Given this list of marker genes PLAT, STX11, IRF8, CAPN2, GRHL1, SIAH2, GCH1, SCGN, SWAP70, MORF4L2, NT5C3A, ZNF837, MFSD2A, DDX60, CRACD, BID, PSMA6, INSIG1, CLCF1, PIM2, CHST7 (carbohydrate sulfotransferase 7), FJX1, TFPI2, TUBB2A, LILRA5, GUCY1B1 (NCBI Gene Id 2983), HSPA13, MAP3K8, TNIP1, FLJ13224, HERC6, MAPKBP1, CD274, CXCL10, WARS1, GRAMD1A, RAB3IP, MMP7, ETV3, SOCS3, GALNT3, RIGI, REL, NAMPT, BCL2, RDX (radixin), PGM3, DDX60L, NETO2, COBLL1, MAP4K4, DYNLT1, LAMA3 (NCBI Gene Id 3909), IL15, IFI27, UBE2Z, KCNJ2, HOMER1, GPR137B, NFKB1, PELI1, EIF2AK2, HIVEP1, BATF, DPP10, WNT4, IDO2, VEGFD, NBN, LYRM1, RAB21, CMTM6, ZBTB17, RPS6KC1, SPRED2, AMIGO2, IRF1, DESI1, AK4, TRAFD1, RGS1, HES4, TNFRSF4, C15orf48, LILRA3, EZH2, LTA, SERPINB1, PXDC1, C17orf58, LINC00930, CLDN1, TNFAIP8, DUSP5, TNFSF8, PLXNC1, PRKAG2-AS2, SELENOI, RELB, BRPF3, MYO10, HLA-DOB, SYNE3, OAS2, TNIP3, SERPINA1, ANKRD22, TBC1D13, AK8, TRIM69, C4orf46, EXT1, UAP1, MT1M, CXCL9, RYBP, IFNB1, AIM2, NUB1, MIR3945HG, RIPK2, IL36G, NEMP1, VCAN, LYSMD2, ALOX15B, JAM2, NEDD4L, SESN3, OPTN (optineurin), GPR157, SNHG15, STAT4, BTG3, LAMB3, IRF7, RAPGEF2, IFIH1, PTGER4, CNKSR3, RHCG, PDE4DIP, TNFAIP2, BIRC2, EHF (NCBI Gene Id 26298), CMPK2, RFTN1, DNAAF1, SERPINB7, SOS1, CCRL2, BTG1, CD200, CHAC1, TARP, RPL36AL, TDRD7, ZNFX1, IFNL1, USP18, ICAM1, TXNL4B, RSAD2, GADD45B, DUSP4, LYN, IFIT1, IRAK2, CXCL3, ADRA1B, SAT1, SEC61G, ITGB8, IQCG, OXTR (NCBI Gene Id 5021), TMEM41A, CSRNP1, NDP, SELENOK, ARAP2, KCNA3, GADD45A, USP12, NCK2, CXCL11 (NCBI Gene Id 6373), LINC02381, DUSP1, NCF1C, PGAP1, TXN, CLDN16, RETREG1, CD70, TOMM34, PARP14, TPBG, UNC5C, here is a description of the gene set: Toll like receptors (TLRs) sense microbial products and initiate adaptive immune responses by activating dendritic cells (DCs). Since pathogens may contain several agonists we asked whether different TLRs may synergize in DC activation. We report that in human and mouse DC TLR3 or TLR4 potently synergize with TLR7, TLR8 or TLR9 in the induction of selected cytokine genes. Upon synergistic stimulation, IL-12, IL-23 and Delta-4 are induced at levels 50-100 fold higher than those induced by optimal concentrations of single agonists, leading to enhanced and sustained TH1 polarizing capacity. Using microarray analysis we show that only 1.5% of the transcripts induced by single TLR agonists are synergistically regulated by combinations of TLR4 and TLR8 agonists. These results identify a combinatorial code by which DCs discriminate pathogens and provide (suggest) a rationale to design adjuvants for TH1 responses. Series_overall_design: 3 untreated, 3 treated with LPS at 2h, 3 treated with LPS at 8h, 3 treated with R848 at 2h, 3 treated with R848 at 8h, 3 treated with LPS + R848 at 2h, 3 treated with LPS + R848 at 8h from publication Napolitani G, Rinaldi A, Bertoni F, Sallusto F, Lanzavecchia A (PMID 15995707) Human Gene Set: GSE2706_UNSTIM_VS_8H_LPS_AND_R848_DC_DN species: Homo sapiens Genes down-regulated in comparison of unstimulated dendritic cells (DC) at 0 h versus DCs stimulated with LPS (TLR4 agonist) and R848 for 8 h.